Given this list of marker genes IGLV3-12, EXOSC3, IFNA6, IFNA4, IGLV11-55, IGLV10-54, TRAV30, TRBV5-7 (NCBI Gene Id 28608), CLEC10A, IGHV1-69, BTK (Bruton tyrosine kinase), IGHV4-39, PRKCD, BRD4, TRAV8-2, TRBV18, IL12A, PIK3CG, USP5, HLA-DRB5, STAT5A, UFL1, TRBC2, JAK1, CD28, HLA-B, TRAV1-1, IGLJ1, NSD2, FCGR3A, TNFSF4, AKIRIN2, TRBV23-1, TRAV39 (T cell receptor alpha variable 39), KLRK1, TNFSF18, IGHJ1, IL7R, BTN3A3, IGLV6-57, IFNA17, TRBV5-6, TRBV24-1, TRPM4, CR1L, IL18R1, TRAV12-3, SLAMF1 (NCBI Gene Id 6504), RIPK3, NFKB2, TRBV10-2, IGHV1-3, EBI3, TNFSF13B, TRBV11-2, SH2D1B, CD8B2, C1QB, CD79B, C5, TRBV10-3, RIPK2, TRAV8-6, IGKV3D-15, TRAV8-4, TRAV24, IGLL1, TRBJ2-2, TRBV14, TRAV7, ALOX15, CLEC4M, TEC, OTUB1, TRAJ42, IGLV2-23, IGHV2-26, ZNF683, DENND1B, IGLV1-36, IGLV1-44, DBNL, SUSD4, CD40, IGKV2-30, TRAV20, TRBV11-1, FCMR, SCART1, NOD2, SHLD1, PARP3, FCGR2C, IL23R, IGKV1D-12, GPR183, ADAM17 (ADAM metallopeptidase domain 17), IGLV3-25, IL4I1, TRBV6-4, IGKV1D-17, IGLV3-16, HPX, IGLC1 (immunoglobulin lambda constant 1), IGKV3D-20, TRBV5-5, IGKV1-39, IRF7, KCNJ8, CAMK4, IGKV1-12, TRAV21, IGHA2, IGHV6-1, IGHV3-64, THEMIS, AZGP1, CTSL, MAPK3, TRGV3, LTA, RC3H1, IL10, IGHV3-64D, SAMSN1, HLA-DQB2, STAT3, CD160, IGHV3-16, HLA-DPB1, CD84, TRBJ2-7, TRAV13-1, PTPN6, OTUD7B, KMT5C, IGLV4-60, TRAV23DV6, EOMES, TLR4 (toll like receptor 4), ARG2, TRBV13, IGKV6D-41, TBX21, IGHV1-69D, CLEC4A, CLEC7A, LY9, MEF2C, SIT1 (signaling threshold regulating transmembrane adaptor 1), SLC15A4, IGLV4-69, CRACR2A, MBL2, BRD2, IL2RB, HLA-DRA, HAVCR2, IGKV1-27, CD8B, IGKV3D-11, TRGV9, TRGV10, TRDV2, PCYT1A, OPA1, LAG3, TFE3, IGLV2-14, IGKV2D-30, TRAV2, HLA-DOB, FCGR1BP, TRBV7-4, TYK2, TRBV4-1, LAT2, IGHV7-4-1, TRDV1, PRKCQ, CD3G, IGHG3, TRGC2, CD86, C7, UNC93B1, RAP1GAP, EXO1, BCL3, EMP2, ICOSLG, TRAV41, TRAV1-2, P2RX7, IFNA16, STAT6, NCKAP1L, C3, HRAS, SHLD2, IL18RAP, CD1B, WAS, PDCD1LG2, PKN1, TRDD1, IGLV2-11, CD80, TNF, IL33, EPHB2, IGKV1D-8, TNFRSF1B, TRAV29DV5, FCER1A, RELB, LILRB1, IGLV3-9, TNFRSF14, NECTIN2, SYK, CD274, BCL6, IL27RA, CLC, MSH2, TREX1, VTCN1, HLA-A, TRBV2, SMAD7, MCOLN2, TRAV19, ADCY7, TRAV3, IRF1, AIRE, EXOSC6, CCR6, IGHA1, ICAM1, IGHV3-23, HMGB1, HLA-DRB1, IGHV4-61, TRBV12-4, NDFIP1, TRBV5-3 (NCBI Gene Id 28612), NLRP10, MALT1, EBAG9 (estrogen receptor binding site associated antigen 9), CLEC4G, MYO1G, C2, RNF168, FOXP3, IFNA21, TRBV6-7, IGLV3-10, PAXIP1, RNF8, C1QA, HMCES, TRBJ2-5, TNFRSF17, IGKV4-1, ENTPD7, ADGRE1, JAK2, TRBV11-3, TRAV13-2, CD3D, DUSP10, RAPGEF4, IFNB1, FCRL4, LEF1, TRBV7-7, IGHV4-28, KLRC4-KLRK1, JAK3, TRAV22, CD1A, TGFB1, SHLD3, TRGV1, ANXA1 (annexin A1), HLA-DMB, CD19, IGKV2-28, FBXO38, TP53BP1, IGKV2D-29, LILRA1, IGKV1D-33, TRAV4, C6, TRAT1, PSG9, LILRB5, FCGR2A, UNG, C8G, IGKV1-9, IGLV3-19, BATF, C1S, TRBJ1-3, TARM1, IL20RB (NCBI Gene Id 53833), C17orf99, IGLV7-46 (immunoglobulin lambda variable 7-46), XCL1, ATAD5, CD70, LILRA3, RC3H2, IGKV1D-42, IL17F (NCBI Gene Id 112744), SEMA4A, IGLC2, TLR8, IL18BP, UNC13D, TRAV8-1, RIF1, FUT7, TRAV27, IFNA7, CLEC6A (NCBI Gene Id 93978), IGKV1-6, IGHV1-45, IGHV1-18, ULBP3, RAET1L, IFNW1, NLRP3, TREM2, IGLV7-43, SASH3, GNL1, CTNNBL1, TRAV12-1, IGLV1-40, TRAV6, TRAV34, HLA-E, IGLV5-52, CD7, TRBV12-3, PRR7, IGHV8-51-1, IGKV2-29, IGHV3-35, C1QBP (NCBI Gene Id 708), CD8A, IGHV1-24, IGHV3-43, IGHV3-15, YWHAG, EIF2AK4, PVR, LOXL3, CD1E, AHR, SLA2, TAP1, IL23A, IL6ST, ERAP1 (endoplasmic reticulum aminopeptidase 1), TRAV35, PAG1, PDCD1, FCRLB, TRBV4-2, TRAV5, IGHV1-69-2, MTOR, HLA-H, TRBJ2-4, NFKBIZ, IL17RA, IGKV2D-28, SLC22A13, IGLV1-47, IL4R, SANBR, FCGR3B, TRBJ1-1, SERPING1, ZC3H12A, IGLV9-49, NOTCH1, STX7, TFRC, TSC1, CTLA4, TCIRG1, TRDC, IGHG4, RORA, TFEB, IGHV3-49, TRBV6-8, IGLC3, ARG1, TRBD1, HLA-G, CTSH, IGLL5, TRBV6-6, TRBV7-6, TRBJ1-6, IL13RA2, IGKV1-13, IGKV1D-43, SWAP70, IGHV3-73 (NCBI Gene Id 28409), IGKV1D-13, TRAV36DV7, CD46, MYD88, TMEM98, LIG4, RFTN1, C8A, TRBV7-3, LGALS9, HLA-DMA, KLHL22 (kelch like family member 22), PRKCB, IGLV2-33, TRAF2, HPRT1, IL4, IGKJ1, IGHV5-51, TRGV5, BACH2, C1RL, ZP3, CARD9, ARID5A, PLA2G4A, IL6, IGHM (immunoglobulin heavy constant mu), ERAP2, IGHG2, JCHAIN, LILRB2, C9, IGHE, CTSC, C8B, BTNL8, IFNA10, CD79A, IGLC6, IFNG, PRKD2, TNFRSF13C, SIPA1, RAET1E, IGLV5-48, TRBJ1-5, IGHV4-59, SLAMF6, IL12B, TRBV3-1, MR1, JUNB, HLA-DOA, CCL19, INPP5D, SH2D1A, TRAC, IGHV3-66, SIRT1, MLH1, IGHV3-13, CYRIB, IGKV2D-26, IGHV3-30 (NCBI Gene Id 652651), NBN (NCBI Gene Id 4683), ZAP70, B2M, TRAV26-2, IGLV3-1, FZD5, IGHV3-74, HLX, TRDV3, IFNK, TRGV8, TNFRSF21, BTLA, CD1D, ITK, RAP1GAP2, IGHV3-33, C1R, CSK, DUSP22, TNFRSF11A, SOCS3, JAM3, CD74, TRAF6, KDM5D, CD209, TREM1, LILRB4, IGHV3-7, EP300, TRBV30, FYN, C1QC, IL18, IGKV2-24, RAG1, TRAV25, IGHV2-70, TRBJ2-6, HLA-C, IGLV3-22, TRAV26-1, RAET1G, IGHV2-70D, TRBV7-1, TXK, IGHV4-31, PMS2, TRAV12-2, MARCHF8, MASP2, IL1R1, IGLV1-50, HLA-DPA1, FCER2, TRBC1, PYCARD, RAPGEF3, IGKV3D-7, MICA, LYN, IGLV4-3, C4A, ZBTB1, IL1RL1, PPP3CB, IL2, CD226, RORC (NCBI Gene Id 6097), BTN3A1, HMHB1, NFKBID, LILRB3, IGHV4-4, TRAV40, TRAV38-1, IGHV2-5, IGKV3-20, STAT4, TRBV9, HLA-DQA1, TRBV12-5, RAB27A, TRAV8-3, IFNE, CD4, TRBV20-1, IGLV1-51, MPEG1, LIME1, TRBV27, CLEC4D, CD27, PHB1, IGHV3-48, CR2 (NCBI Gene Id 1380), PTPRC (NCBI Gene Id 5788), ULBP2, TRBJ1-2, CLU, IFNA14, HSPD1, MICB, BCL10, CSF2RB, FGL1, SIGLEC10, CADM1, IL9R, PRF1, PDIA3, TRBJ1-4 (T cell receptor beta joining 1-4), CEACAM1 (NCBI Gene Id 634), CD247, KLRD1, PRDM1, SLC11A1, ORAI1, TRDJ1, KLHL6, LILRA6, TRGV2, C4BPA, ADA, IGHV3-21, HLA-DRB4, TRGV4, TRBV17, TRAF3IP2, IGHV3-11 (NCBI Gene Id 28450), IGKC, IGHD, TRBV16, TRBJ2-1, TNFRSF13B, ZBTB7B, TRAV9-2, TRAV9-1, TNFAIP3, TRGV11, CD6, PIK3CD, SECTM1, BTN3A2, TRAJ3, FCGR1A, SUPT6H, CFI, TRAV10, IGHD1-1, TRAV14DV4, TNFSF13, CD1C, CD81, TAP2, IFNA5, LAX1, IGKV1-37, IGLV8-61, TRAV17, IGKV1D-39, CCR2, IGKV2D-24, LAIR1, CD69, KMT5B, IGHV3-20, IL6R, ASCL2, CRTAM, SLAMF7, HLA-DRB3, LAT, IGLV3-21 (immunoglobulin lambda variable 3-21), GATA3, CTSS, IGHV7-81, CXCL13, GZMM, MAP3K7, IL27, IFNA1, TRBV10-1, TRIM27, AICDA, PRKCZ, PTK2B, IGKV5-2, IFNA8, IGHV3-72, TRBV6-5, MAD2L2, BMX, TRBV5-1, CD244, FOXJ1, LGALS1, FADD, FGB, TRAV38-2DV8, IGHV3-38, TRBJ2-3, TRAJ31 (NCBI Gene Id 28724), IGKV1-8, IGKV1-5, TRGC1, HLA-DQA2, IL12RB1, CR1, SPN, IGLV2-8, ULBP1, IGLV3-32, IGLV2-18, IGKV3-7, ERCC1, CLCF1, TRBV7-9, IGHV1-58, GFUS, IGHV3-53 (NCBI Gene Id 28420), TRAV18, LAMP3, IGKV2-40, TRBV29-1, IL17A, RNF19B, IGHV4-34, SOCS5, IGLV5-45, PRKAA1, MSH6 (NCBI Gene Id 2956), IL9, IGKV6D-21, IGKV1-17, IGKV6-21, CLEC4C, KLRC2, HLA-F, IGLC7, ALCAM, C4B, CX3CR1, RNF125, IGKV1-16, NEDD4, IL1B, SKAP1, TRBV5-4, TRAV16, MIR21, KLRC1, TRBV19, TRBV7-2, FCGR2B, AGER, C4BPB, HFE, IGLV5-37, RSAD2, IGLV3-27, MCOLN1, TRBV25-1, CD40LG, JAG1, FGA, IGKV3-15, IGHG1, TRBV6-1, DCLRE1C, IRF4, CD55, TRBV28, IFNA2, IGHV5-10-1, CD3E, FCAMR, APLF, FCER1G, IGKV1D-37, HLA-DQB1, here is a description of the gene set: An immune response mediated by cells expressing specific receptors for antigens produced through a somatic diversification process, and allowing for an enhanced secondary response to subsequent exposures to the same antigen (immunological memory). studied in species Homo sapiens Human Gene Set: GOBP_ADAPTIVE_IMMUNE_RESPONSE